The following is a description of a gene set: Formation of the nephric duct Human Gene Set: REACTOME_FORMATION_OF_THE_NEPHRIC_DUCT studied in species Homo sapiens, and this is the list of marker genes: WFDC2, RET (ret proto-oncogene), PCDH19, GATA3, EMX2, MECOM, NPNT, BMP4, OSR1, HOXB4, PAX8, PLAC8, PAX2, LHX1, ID4, HOXA6, FGF2, CTNNB1